The following is a description of a gene set: species: Homo sapiens Human Gene Set: REACTOME_PHASE_3_RAPID_REPOLARISATION Phase 3 - rapid repolarisation, and this is the list of marker genes: AKAP9, KCNE5, KCNE3, KCNE4, KCNE2, KCNA5, KCNQ1, KCNE1, KCNH2